The following is a description of a gene set: Human Gene Set: MIR3152_3P species: Homo sapiens Genes predicted to be targets of miRBase v22 microRNA hsa-miR-3152-3p in miRDB v6.0 with MirTarget v4 prediction scores > 80 (high confidence targets). from publication Chen Y, Wang X (PMID 31504780), and this is the list of marker genes: DHX8, NR4A1, BICD2, CPT1A, MED29, GORAB, ZNF577, ZNF582, KIAA1958, GAB1, DNAJC21, CNNM1, C9orf72, FAM120AOS, NKAIN2, SPTBN1, EMX2 (NCBI Gene Id 2018), SCUBE3, KCNMB2 (NCBI Gene Id 10242), TIGD6, ATF6 (activating transcription factor 6), PTPRD, HEATR5A, ZNF235, ANK2, ASPH, KLF6, COL4A1, FOXD4L5, MUC21, BHLHE41, ZNF550, RLIM, CYTL1, CYB5R2, CD40LG, PLOD2, CPEB3, RFPL4B, DPPA4, AKR1C2, RRAGC, PLXDC2, LANCL2, P4HA1 (NCBI Gene Id 5033), RNF39, BARD1, CFAP300, IGF2BP3, SEM1, GPR171, PRKAB2, MBTD1, TTF2, ADAMTS6, PRRC1, KLF3, SNX3, PLXNC1, KCNA7, PLAUR, KBTBD8, TGFBR1, PPBP, CLDN1, C15orf62, MMP1, ZNF609, SYCP3, RHPN2, BATF2, ECM2, GGPS1, CNTD1, TSC22D2, CEP44 (centrosomal protein 44), RYK, MTHFD2L, SEPTIN7, ZNF37A, ZNF853, CLDN11, MOSPD1